The following is a description of a gene set: Human Gene Set: MODULE_272 Genes in the cancer module 272. studied in species Homo sapiens, and this is the list of marker genes: ALDOA, ADH4, ALDH1L1, MTHFR, MTHFD2, ODC1, PAICS, BLVRB, PYCR1 (pyrroline-5-carboxylate reductase 1), MTHFD1, ALDH4A1, UMPS